The following is a description of a gene set: Marker genes curated from the annotated cluster as represented in the Descartes Human Gene Expression During Development database. The gene expression program underlying the specification of human cell types is of fundamental interest. The study authors generated human cell atlases of gene expression and chromatin accessibility in fetal tissues. For gene expression, the study authors applied three-level combinatorial indexing to >110 samples representing 15 organs, ultimately profiling ~4 million single cells. The study authors leveraged the literature and other atlases to identify and annotate hundreds of cell types and subtypes, both within and across tissues. Our analyses focused on organ-specific specializations of broadly distributed cell types (such as blood, endothelial, and epithelial), sites of fetal erythropoiesis (which notably included the adrenal gland), and integration with mouse developmental atlases (such as conserved specification of blood cells). These data represent a rich resource for the exploration of in vivo human gene expression in diverse tissues and cell types. studied in species Homo sapiens Human Gene Set: DESCARTES_FETAL_SPLEEN_AFP_ALB_POSITIVE_CELLS from publication Cao J, O'Day DR, Pliner HA, Kingsley PD, Deng M, Daza RM, Zager MA, Aldinger KA, Blecher-Gonen R, Zhang F, Spielmann M, Palis J, Doherty D, Steemers FJ, Glass IA, Trapnell C, Shendure J (PMID 33184181), and this is the list of marker genes: LSS, ELOVL2, AGXT, ANGPTL3, F10, ASGR1, SMLR1, HAL, LIPC, GC, TMEM199, AZGP1, H19, SULT1C2, TM4SF4, VTN, C8A, SLC38A4, APOE, ABCC6, PRAP1, DLK1, PRLR, HNF4A, GAMT, HMGCS2, GRHPR, ALDH6A1, SLC25A10, GSTA1, A1CF, IGSF1, PCBD1, SDC1, HGFAC, SLC39A5, F5, GPC3, CYP19A1, FTL, FGG, SPP2, F7, SLC13A5, TRIM71, AHSG, BHMT2, APOM, SLC39A14, DHCR24, SERPINF2, ATF5, FTCD, SERPINA5, HPN, ACAA1, CYP4F3, MSMO1, ACSL4, CYB5A, SERPINA3, DNAJC12, FST, HRG, FMO5, SLC38A3, FGB, LINC02532, MASP2, AGAP5, CYP4A11, MT2A, C2, C8B, ITIH2, FN1, MSRB1, ASGR2, APOC1, PBLD, MT1F, MT1G, HAMP, SERPINA1 (serpin family A member 1), CPS1, SPRYD4, UGT2B4, CRYZ, COL2A1, SNAP25-AS1, TM7SF2, MAT1A, FGL1, RBKS, FABP1 (NCBI Gene Id 2168), CYP3A5, GALK1, TMEM150A, HPX, ALB, TTR, ITIH1, BEX1, LBP, HMGCS1, SERPINA6, KTN1-AS1, APOC3, APOA2, DGCR6L, ALDOB, PTP4A1, PAH, AFP, SERPIND1, ACADSB, PCYT2, ADORA2A-AS1, RBP4, F12, SULT1E1, AMN, MTTP, APOB, MT1X, LRG1, APOH, KNG1, RETSAT, HABP2, MST1, SERPINA4, GLDC, MGST1, PLG, AMBP, IGFBP1, ADH6, PEG10, GLUD1, IGF2, PEBP1, PKHD1, ACSM2B, SLC2A2, CLU, SCD, SLC22A9, AGT (NCBI Gene Id 183), APOA1, ADH1A, CYP3A7, ITIH3, TRIM32, TMEM97, DPYS, FGA, C5, GATM, PHYH, CDO1, PERP, SERPINC1, CHDH, LINC01428, CFHR1 (complement factor H related 1), DHCR7, FXYD1, ALDH4A1 (aldehyde dehydrogenase 4 family member A1), SLC27A2, KLKB1 (NCBI Gene Id 3818), AGPAT2, GJB1 (NCBI Gene Id 95372), SC5D, FXYD2, TMT1A, SERPINA7, GPAM, F2, LOXL4, CYP51A1, TF, DUSP9, DGAT2, NPSR1-AS1, MT1H, MT1E, ADH4